Given this list of marker genes LRP5 (LDL receptor related protein 5), EXT2, GABBR2, MPV17 (mitochondrial inner membrane protein MPV17), TFG, ERLIN2, LMNA (lamin A/C), BVES, CACNA1A, GOSR2, POMT1, MT-ATP6, UCHL1, PLEC, SELENON, HINT1, VAPB, VPS16, HMGCR, LARGE1, POLR3B, CDKL5, ALDH18A1, POMT2, PRX, SBF1, GFM2, CRAT, NUP54, SDHD, EIF2B5, LRP12, MYH7 (myosin heavy chain 7), VPS13C, DES, EPRS1, TK2, MECP2 (methyl-CpG binding protein 2), SMC1A, NUP62, FOXRED1, SNUPN, NTNG1, LYRM7, ERBB4, GMPPB, MECR, RRM1, TWNK, IRF2BPL, EIF2B3, SDHA, LDB3, KLHL9, HYCC1 (NCBI Gene Id 84668), VCP, MCM3AP, PANK2 (NCBI Gene Id 80025), RILPL1, GDAP1, NFU1, DYSF, GLRX5, RNASEH1, MYOT, TGM6, SIGMAR1, FKRP, PSAP, CLN3, POLR3A, AP4S1, DNAJB6, SNCA, COQ4, ACTB, SPTAN1, MTMR14, TRIM32 (NCBI Gene Id 3971), ALS2, GPRC5B, VAC14, PEX1, DNAJC6, NDUFA6, REPS1 (RALBP1 associated Eps domain containing 1), CLN8, ITPR1, ADAR, POLR1A, FARS2, SLC9A6 (solute carrier family 9 member A6), LETM1, JAG2, HK1, SMN2, HSD17B10, PEX11B, C19orf12, PEX16, CRPPA, GNPTAB, RRM2B, CHRND, HNRNPA2B1, GIPC1, SMN1, SGCB, EMD, CLN5, PRKN, DARS2, ADAM22 (NCBI Gene Id 53616), COQ2, CAPRIN1, DSTYK (NCBI Gene Id 353293), SAMD9L, MARS2, APTX, SCO2, NOTCH2NLC, MAG, HMBS, HNRNPA1, DMD, SDHAF1, NEU1, PLP1, GGPS1, NKX6-2, CAPN1, SDHB, SUCLA2, PLA2G6, OPTN, SGCG, GALC, FHL1, SLC39A14, SPTLC1, VPS13A, DNM2, FA2H, MAPT, POGLUT1, here is a description of the gene set: Human Gene Set: HP_LOSS_OF_AMBULATION Loss of ambulation studied in species Homo sapiens Inability to walk in a person who previous had the ability to walk.